Given this list of marker genes KCTD4, GSK3B, ENOX1, GRIK2 (NCBI Gene Id 2898), HOXA3, DHX38, PPP2R3A, RNF213, ZIC1, SCRG1, KCNH8, TWIST1, RUNX1T1, NUP107, CHCHD7, KCNQ4, PKP4, PLAG1, ANGEL1, PRELP, MYCL, GJB1, NKX6-1, SLC6A4, EDC4, ZIC4, OTULINL, TRPS1, ANKMY2, CDC42EP3, CHAD, SOX5, ANXA2, EFNA1, HOXD10, LINC00310, TENM1, HOXC11 (NCBI Gene Id 3227, homeobox C11), GRK5, CTAGE1, PAQR4, AKT3, FOXP3, GPM6A, JMJD1C, SMG1, NHSL2, NKX2-8, MANF (mesencephalic astrocyte derived neurotrophic factor), FOXP2, ZNF41, WNK4, HOXB6, PALS2, BZW2 (NCBI Gene Id 28969), ABLIM1, RFLNB, NUDCD1, MMP14 (matrix metallopeptidase 14), LAMA4, OLIG3, ARRDC3 (arrestin domain containing 3), TIMP4, WNT2, PC (NCBI Gene Id 5091), CALD1, CORO1C, ITGB5, STX18, MAG, ZNF503, TXNL4B, NOVA1, SWAP70, DNAH8, SIRT6, NEUROG1, IGSF21, HIPK1, MATN1, ADAMTSL1, SETD2, ZC3H6, TBL1X, RARG, here is a description of the gene set: Human Gene Set: RYAAAKNNNNNNTTGW_UNKNOWN Comprehensive identification of all functional elements encoded in the human genome is a fundamental need in biomedical research. Here, we present a comparative analysis of the human, mouse, rat and dog genomes to create a systematic catalogue of common regulatory motifs in promoters and 3' untranslated regions (3' UTRs). The promoter analysis yields 174 candidate motifs, including most previously known transcription-factor binding sites and 105 new motifs. The 3'-UTR analysis yields 106 motifs likely to be involved in post-transcriptional regulation. Nearly one-half are associated with microRNAs (miRNAs), leading to the discovery of many new miRNA genes and their likely target genes. Our results suggest that previous estimates of the number of human miRNA genes were low, and that miRNAs regulate at least 20% of human genes. The overall results provide a systematic view of gene regulation in the human, which will be refined as additional mammalian genomes become available. from publication Xie X, Lu J, Kulbokas EJ, Golub TR, Mootha V, Lindblad-Toh K, Lander ES, Kellis M (PMID 15735639) Genes having at least one occurrence of the highly conserved motif M151 RYAAAKNNNNNNTTGW in the regions spanning 4 kb centered on their transcription starting sites. The motif does not match any known transcription factor binding site. studied in species Homo sapiens